Given this list of marker genes COL4A4, SPMAP1, CCDC171, H2AP, HBZ, RLN1, SH3GL1P1, ZNF527, COX7A1, C1QTNF1-AS1, ABCA8, POU2F2, B3GNT9, C9orf50, LINC02873, FAM83H, PAPPA2, GCK, TEKT1, MAGEB1, ABCD2, MFF-DT, RACGAP1P1, RPH3AL, RGL2, DELE1, FSD1, SLC6A18, DNAH8, SPANXC, SIRT6, WDR87, NPAP1, LINC01973, SEMA3F, SPINK2, LAMA3, USP26, TSSK2, LINC02579, AKAP14, ROBO2, DIRC3, CTNND2, BRD7P3, COX8C, TFF3, CLEC14A, FGF6, NPTXR, SPAG6, FITM1 (fat storage inducing transmembrane protein 1), ACSM2A, LCE1B, CCDC24, FBXO2, MPZL2 (myelin protein zero like 2), PYGM, DMRT2, DHRS7C, ADRA2B, FGF22, GGT7, TXNDC2, NXPE1 (NCBI Gene Id 120400), SPEM1, CFAP69, RBM8A, IL26, TRIM50, PLK5, TUB, MYRFL, RNF32-DT, TAL1, VGF, HSD11B2, IL18R1, GATA2-AS1, CORO6, CCDC80, C12orf54 (NCBI Gene Id 121273), PRDM16-DT, TBC1D10A, ASPG, C8orf74, KISS1, ARHGAP44, PPY, R3HDML, CBY2, CHRD (NCBI Gene Id 96177), ATP6V0A4, BARHL1, FLJ40288, DPY19L3-DT, CNTNAP2, ABCA3, CLDN17, DDX4, RNF148, DEFB125, MAP1S, TEX46, MSANTD1, IRGM, ANGPTL1, TPT1P8, RAB11FIP3, C10orf90, P2RY12, CSRP3, SURF2, LORICRIN, SEMA3G, NR2F1, HCRTR1, XIRP2, C10orf67 (chromosome 10 open reading frame 67), BFSP2-AS1, CSTF2, NOS1AP, SYCN, MIX23P3, CLTCL1, TMEM225, AHI1-DT, CYP2C18 (NCBI Gene Id 1562), RSPH9, FAM43A, ZBBX, OR7A17, HHATL, KLHL17, ZFR2, ABCG4, SEMA5A, GUCY2C, RDH8, PAPOLB (NCBI Gene Id 56903), ITIH3, TEAD4, FAM47A, PLA2G12B, LINC01098, HTR4, HOXB1, SLC30A3, CCDC116, CPTP, TMEM14A, SAXO2, C1RL, TNFRSF19, FXYD4, PCDHA3, TMEM132A, NGFR, METTL27, ELAPOR1, FAHD2A, TANC1, CIMAP2, TMEM191A, HFM1, RFX4, AP1M1, AIF1L, BSND, MSL1, NOBOX, PCDHGB7 (NCBI Gene Id 56099), SHISA9, AGXT2, PLEKHH3, PRR22, LINC01704, LGI4, B3GAT1, DOC2A, TMEM92, BMP8B, LY6H, GOLGA6A, here is a description of the gene set: Human Gene Set: GSE46606_UNSTIM_VS_CD40L_IL2_IL5_3DAY_STIMULATED_IRF4_KO_BCELL_UP studied in species Homo sapiens Temporal analysis of B cell activation in vitro using CD40L and IL-2/4/5 cytokines in wild type Irf4+/+ B cells or in mutant Irf4-/- B cells harboring a tet-inducible allele of Irf4. IRF4 expression was restored, or not, in the Irf4-/- background by culturing in the presence of low or high concentrations of doxycycline. The results provide insight in the role of IRF4 expression levels in coordinating different programs of B cell differentiation. Genes up-regulated in at day 0 B cell IRF4-KO versus CD40L and IL-2 IL-4 IL-5 stimulated at day 3 B cell IRF4-KO. from publication Ochiai K, Maienschein-Cline M, Simonetti G, Chen J, Rosenthal R, Brink R, Chong AS, Klein U, Dinner AR, Singh H, Sciammas R (PMID 23684984)